Given this list of marker genes PLCB3, GNG5, GNG4, GNG10, GNG7, GNB4, PLCB1, GNB3, GNB2, GNB1, GNB5, GNG3, GNG12, GNG13, GNG8, GNGT2, GNGT1 (G protein subunit gamma transducin 1), PLCB2, GNG11, GNG2, here is a description of the gene set: Phospholipase C beta (PLCbeta) isoforms are activated by G-protein beta:gamma in the order PLCB3 > PLCB2 > PLCB1. Gbeta:gamma binds to the pleckstrin homology domain of PLC beta, increasing phospholipase activity and leading to increased hydrolysis of PIP2 to DAG and IP3. part of: G-protein beta:gamma signalling Reactome Pathway: G beta:gamma signalling through PLC beta species: Homo sapiens